Given this list of marker genes Idh2, Hyi, Agxt, Idh1, Mgat4a, Hoga1, Grhpr, Agxt2, here is a description of the gene set: species: Mus musculus The chemical reactions and pathways involving glyoxylate, the anion of glyoxylic acid, HOC-COOH. Mouse Gene Set: GOBP_GLYOXYLATE_METABOLIC_PROCESS